The following is a description of a gene set: species: Homo sapiens Ubiquinol biosynthesis Human Gene Set: REACTOME_UBIQUINOL_BIOSYNTHESIS, and this is the list of marker genes: COQ6, COQ8B, COQ9, PDSS2, COQ8A, COQ2, COQ5, COQ7, COQ3, PDSS1, COQ4, STARD7 (NCBI Gene Id 56910, StAR related lipid transfer domain containing 7), HPDL